The following is a description of a gene set: Binding to an antigen, any substance which is capable of inducing a specific immune response and of reacting with the products of that response, the specific antibody or specifically sensitized T-lymphocytes, or both. Binding may counteract the biological activity of the antigen. Antigen binding by an MHC protein complex allows the antigen to be displayed to a T cell or NK cell. Human Gene Set: GOMF_ANTIGEN_BINDING studied in species Homo sapiens, and this is the list of marker genes: PLG, IGHV4-34, IGHV1-3, SIRPA, IGHV3-30, HLA-DRB5, IGLV2-14, TRGV9, SLC7A8, IGHV2-70, IGKV1-16, IGLV2-11, TRAV12-3, IGHV4-4, CD209, IGKV1D-12, IGKV3-15, IGHV1-69, IGHV3-64D, IGLV3-27, HLA-DMA, TSPAN4 (tetraspanin 4), IGKV2-30, IGKV5-2, HLA-DOB, IGLV3-21, IGHV7-81, HFE (homeostatic iron regulator), IGHV3-66, IGLV3-25, HLA-DOA, IGHV3-33, IGHV3-64, TAPBP, IGHV7-4-1, HLA-B, IGHG2, IGHV6-1, FCN2, IGHV3-15, IGKC, HLA-DQB1, IGHM, TRGV3, KIR2DL3, HLA-DMB, HLA-G, IGLV2-8, IGHV1-69-2, HLA-DRA, HLA-DQB2, IGHV1-24, IGHV3-53, LILRA2, IGHV4-59, IGLV6-57, IGHG4, IGHV1-45, TRAV23DV6, IGHV3-16, IGHV1-69D, IGKV1-5, IGLV1-40, IGHV5-51, IGLV1-47, IGHV3-13, IGKV4-1, IGHV8-51-1, HLA-F, IGHV3-74, ITGA4, IGHV3-72, IGKV1-17, TRBV7-9, TRAV19, IGKV1D-39, HLA-DRB1, FCN1, IGLC1, IGHV3-73, B2M (beta-2-microglobulin), CLEC4M, TRAV12-2, IGHV3-7, IGLC2, IGHD (immunoglobulin heavy constant delta), CD1C, IGHV3-43, IGHV2-5, IGHV1-18, KLRD1, MAML1, IGHA1, IGHV3-11, IGHV1-58, IGHG1, HLA-DQA1, GP2, ABO, TRBV12-3, IGHV3-49, HLA-DPB1, TRAV29DV5, IGKV2D-28, IGHV3-23, IGLV3-19, PPP2R1A (protein phosphatase 2 scaffold subunit Aalpha), HLA-H, SLC7A5, DHCR24, TAP1, LILRA1, IL7R, HLA-A, HLA-DPA1, HLA-DQA2, IGHG3, IGHA2, IGLV3-1, CD1A, SLC7A9, IGHE, KLRC1, IGLV1-44, IGHV4-61, LAG3, IGHV2-26, HLA-E, IGLL1, IGHV3-20, IGHV3-21, TRAV12-1, TRBV28, IGHV3-35, CD1B (NCBI Gene Id 910), FCGRT, IGHV4-39, IGLC3, FCN3, IGKV1-39, LCK, IGLL5, IGHV3-38, IGHV4-28, IGKV1D-33, CD1E, EP400, TRAV8-4, SLAMF1, JCHAIN, HLA-DRB4, IGHV3-48, CD40, HLA-DRB3, HLA-C, IGHV4-31, TOPORS, IGLV2-23, IGLC7, IGLV1-51, SPON2, IGHV5-10-1, CD1D, IGHV2-70D, KLRC2, IGKV3-20, TAP2, IGLV7-43, IGLC6